Given this list of marker genes SYK, IGHM, CD79B, CD79A, LIME1, IGHE, here is a description of the gene set: species: Homo sapiens Human Gene Set: GOCC_B_CELL_RECEPTOR_COMPLEX An immunoglobulin complex that is present in the plasma membrane of B cells and that in its canonical form is composed of two identical immunoglobulin heavy chains and two identical immunoglobulin light chains and a signaling subunit, a heterodimer of the Ig-alpha and Ig-beta proteins.